Given this list of marker genes ARHGEF17, MYCBP2, FGD5, HPS4, RABGAP1, AGAP2, RIC1, ELMOD1, TBCK, ARAP2, ARHGAP15, SYNGAP1 (synaptic Ras GTPase activating protein 1), RASGRP3, AGAP6, CYTH2, RAPGEF4, PSD, DOCK8, TBC1D22A, RGS14, WAS (NCBI Gene Id 7454), SLC38A9, RASGEF1A, RGPD5, TBC1D30, AKAP13, RGS7, ARAP3 (NCBI Gene Id 64411), SH3BP1, DOCK2, ECT2, IQSEC2, RALGAPA1, GNAQ, TBC1D4, ARRB1 (arrestin beta 1), STARD13, TBC1D1, PREX1, RALGAPB, TBC1D26, RAPGEF2, TBC1D13, PCP2, RGS4, ACAP3, LLGL1, ALS2, DENND4A, FARP1, ECT2L (NCBI Gene Id 387075), ARHGAP11B, SRGAP1, RGS5, SH2D3A, SYDE1, RGPD2, RABIF, PSD4, ARL2BP, MCF2, RALGDS, DOCK3, ITGB1BP1, ARHGAP36, AGAP4, OCRL, ARHGAP25, ARHGEF40, RIMS1, RABGAP1L, PLEKHG3, ARHGAP28, RIN3, RASAL3, SIPA1L3, SH3BP5L, DNM1L, RASGRP1, THG1L, EIF2B3 (eukaryotic translation initiation factor 2B subunit gamma), CHN1, PLEKHG4B, ARHGAP39, ARHGAP19, RAB3IP, DEPDC1, RGS6, ARHGAP21, RANBP10, SEC23B, ARHGAP20, RASGEF1C, ARHGAP29, RGS18, TBC1D9B, ARHGAP4, ARHGEF25, TBC1D15, RAB3IL1, PREX2, TBC1D10A, NRP1, SGSM2, SBF1, PLEKHG5, ARHGAP18, RAP1GDS1, RACGAP1 (NCBI Gene Id 94651), SPATA13, EIF2B2, TBC1D9, SOS2 (NCBI Gene Id 96829), TBC1D3C, SEC23A, GRTP1, RGPD1, ARHGAP17, TBC1D3H, ARHGAP26, ARHGEF37, FLCN, SLIT2, HACD3, RGS20, ARHGEF3, TAGAP, ARF4, GNA13, CDC42EP2, DOCK9, STXBP5L, CYTH4 (NCBI Gene Id 29776), ALDH1A1, RAPGEF3, VAV1, VAV3, TRIO, DIS3, ACAP1, PSD3, ARHGEF2 (NCBI Gene Id 9181), TBXA2R, DNAJA3, EPS8L2, ASAP1, ARHGAP35 (NCBI Gene Id 79266), IQGAP2, KRIT1, SRGAP2, DOCK4, GPSM1, RCC1, RHOH, DENND10, LARS1, STXBP5, DENND5B, ARHGAP10, RIN2, DAB2IP, ALS2CL, ARHGAP24, MCF2L2, RGS1, MYO9B, HMGCR, IQSEC3, PLCB1, RASA3, RABGEF1, LRRK2, RANGRF, TBC1D10B, EPS8L3, ARHGEF1, PLEKHG7, OPHN1, EIF2B4, ADAP1, RALGAPA2 (NCBI Gene Id 79617), RTKN, DOCK1, RP2, TBC1D12, HERC2, NCKAP1L, ITSN1, LAMTOR2, RGS11, CHN2, ARHGEF4, GPSM3, ARHGEF12 (NCBI Gene Id 55406), FRMD7, TBC1D8B, EPS8L1 (NCBI Gene Id 54869), RAB3GAP1, BCR, RCC1L, DEPDC5, ARHGAP44, DENND11, CDC42SE1, ARHGAP5 (Rho GTPase activating protein 5), TBC1D2, ARHGEF11, FGD1, GPSM2, DEPDC1B, OBSCN, ARHGEF10L, TBC1D16, TSC2, ARHGEF15, IQGAP3, LAMTOR3, ACAP2, VPS9D1, DENND3, TBC1D7, ARHGEF19, RAPGEFL1, ARHGEF7, RALBP1, LAMTOR5, RGPD4, DENND2A, VAV2, FGD6, EEF1D, ARHGEF39, HERC1, AGAP5, ADRA2A, ARHGAP22, RASGRF1, ARHGDIB, RASAL2, RGS8, HTR2B, RANBP1, RASGRP4, ARHGEF38, ADAP2, RANBP2, PTGIR, ARHGEF5, RGPD6, DOCK5, USP6NL, ARHGAP23, GPS1, DOCK10, RGS2, RIN1, DENND5A, EVI5, TBC1D3G, P2RY12, SIPA1L2, PLCE1, RABEP1, RGS9, DOCK11, CHM, DNMBP, NF1, RCC2, AGAP7P, TBCD, WDR41, PLCG1, C9orf72, RAPGEF6, DEPTOR, RIC8A, SESN2, TBC1D22B, ELMOD2, PLEKHG4 (pleckstrin homology and RhoGEF domain containing G4), JUN, FARP2, SERGEF, RGS12, RAPGEF1, DENND2C, TIAM1, RAP1A, TBC1D5, ARHGAP33, SYDE2, ARHGAP11A, CPEB2, KNDC1, TBC1D3E, TBC1D8, SIPA1L1, RGL4, CCDC88A, WASL, RGS3, TBC1D3, ARHGDIG, GPS2, PLEKHG6, ELMOD3, ARHGAP31 (Rho GTPase activating protein 31), PDE6D (NCBI Gene Id 5147), GIT2, MYO9A (myosin IXA), FAM13B, PLXNB1, FGD4, DENND1B, ERRFI1, CYTH1 (NCBI Gene Id 9267), TBC1D3B (TBC1 domain family member 3B), RASA4, RASA1, GRB2, SMAP1, DEF6, RGL1, SMAP2, FAM13A, GDI1, AGAP11, ARHGEF10, TNK2, ARHGAP32, IQGAP1, RAP1GAP2, ADGRB3, ARHGEF26, TBC1D3L, RAPGEF5, TBC1D10C, EIF2B1, RGPD8, RASGEF1B, MON1A, GIT1, RANGAP1, ARHGAP12, NPRL3, ARHGAP40, ARHGAP6, CCZ1, SEC61B, ARHGEF9, PLEKHG2, FGD2, TBC1D24, ARHGAP30, ARHGEF28, PLCD4, MCF2L, TBC1D21 (NCBI Gene Id 161514), NUCB2, LAMTOR4, RGS17, AGAP1, RGS16, ARHGDIA, ADRA2C, NUCB1, ARFGAP2, IPO7, FGD3, RGL2, RGL3, ARFGEF3, EEF1B2, TBC1D3D, AGFG2, ARHGAP8, ARHGEF18, SIRPA, RINL, SH2D3C, ARFGAP3, TBC1D2B, TBC1D25 (TBC1 domain family member 25), ARFGAP1, RGP1, CHML, RABEP2, ELMO1, RASA2, DENND6B, GMIP, SWAP70, DOCK7, GRIPAP1, LAMTOR1, ARHGEF6, DENND1C, RHOF, ARHGAP27, SH3BP4, RASA4B, DOCK6, TBC1D14, ASAP2, RUNDC3A, PLEKHG1, SGSM1, ASAP3, RASAL1, EIF2B5, EGF, RIC8B, SOS1, MTSS2 (MTSS I-BAR domain containing 2), KALRN, ANKRD27, ARHGEF16, FBXO8, IQSEC1, BCAR3 (BCAR3 adaptor protein, NSP family member), NPRL2, TBC1D3K, EIF5, RHOU, AGAP3, DLC1, DENND4C, SIPA1, EVI5L, RPGR, RALGPS2, NET1, IPO5, DENND4B, NGB, TBC1D17, NGEF, ARHGAP1, GCGR, ARHGAP42, GNB5, ARHGAP9, BNIP2, STARD8, ITSN2, RALGPS1 (NCBI Gene Id 9649), SGSM3, ARHGAP45, ABR, RASGRF2, TBC1D3I, LLGL2, CYTH3, ARFGEF1, HPS1, MADD, SH3BP5, GDPGP1, SRGAP3, DENND1A, GAPVD1, RCBTB2, PDGFRB, TBC1D20, RAP1GAP, SMCR8, TBC1D19, THY1, RGPD3, PREB, TIAM2, AGFG1, ARHGEF33, TBC1D3F, RASGRP2, DENND6A, CCDC88C, AGAP9, ARFGEF2, PSD2, ARAP1, DENND2B, RGS10, KIAA1755, RAB3GAP2, PELO, GARNL3 (GTPase activating Rap/RanGAP domain like 3), DENND2D, GDI2, SBF2, RHOD, GBF1, here is a description of the gene set: Binds to and modulates the activity of an NTPase. Human Gene Set: GOMF_NUCLEOSIDE_TRIPHOSPHATASE_REGULATOR_ACTIVITY species: Homo sapiens